The following is a description of a gene set: The process whose specific outcome is the progression of an erythrocyte over time, from its formation to the mature structure. species: Homo sapiens Human Gene Set: GOBP_ERYTHROCYTE_DEVELOPMENT, and this is the list of marker genes: EPB42 (erythrocyte membrane protein band 4.2), BAP1, ADGRF5, RAC1, BPGM, L3MBTL3, TRIM58, HEATR3, SLC11A2, ALAS2, FAM210B, NCKAP1L, DIAPH3, SLC4A1, CITED2, ERCC2, TMOD3, HBZ, TAL1, HDAC6, SRF (NCBI Gene Id 6722), NEMP1, GATA1, BRD1, RHAG, MAEA, FLVCR1, SLC25A40, BCL6, PTBP3, SH2B3, KLF2, ABCB10, RAC2, RHEX, JMJD6, ARID4A, PLA2G10, EPO, MED1, ALAS1, ZBTB7A, G6PD, DMTN, LYAR